Given this list of marker genes PPCDC, NOL9, TP53I3, TRAJ7, COX14, GALE, MIDEAS, SNHG1, CPHL1P, LINC02895, CDK12, CREM, VN2R3P, INTS4, CFAP418, ITK, FHOD3, ACSS2 (NCBI Gene Id 55902), COL7A1, LINC01098, CCDC18-AS1, LINC00511, ABCG1, XDH, SLC27A4, ZDHHC18, GDNF-AS1, RARA, FPR1, SALL4, CTDSPL2, SLC22A4, RPS3A, ENSG00000267174, SHKBP1, SLCO2B1, RACK1, RPL5, ZNF217, RNVU1-31, PIGT, STMN3, IKBKB-DT, RAPGEF6 (Rap guanine nucleotide exchange factor 6), SDK2, AP3S2, MATN1-AS1, ZMIZ1, PPP6R1, RFX2, MAP4K3-DT, ARMC1, DIAPH1-AS1, IMPDH1P10, OMG, SPATS2, GARS1-DT, SLC25A22, SNORD96A, EIF3F, RN7SL672P, WWTR1, ZBP1, FKBP14-AS1, COPS4, CTHRC1, OSER1-DT, LINC03033, BCAS3, ABCB9, SLC11A2, RYR2, ENDOV, ILF3-DT, ZNFX1, SRP14-DT, PARP2, COL16A1, SNHG11, RNF26, RNU7-136P, RBM22, TSSC4 (NCBI Gene Id 10078), ZFAS1, KRTAP2-4 (keratin associated protein 2-4), CCNT1, CFDP1, LINC02098, ACOT7, TRAPPC4, YJU2B, ENSG00000227496, RAB27A, PPFIA1P1, TRIB1, AIG1, EIF4A3, KLKP1, TLDC2, C9orf72, ALKBH3-AS1, CMAS, CFLAR-AS1, SNORD12C, PKIG, SNRPD1, RPS25, SMAD3, ZNF22-AS1, SP2-AS1, KRT80, SPOP, WDR62, LINC02952, KIR2DL4, SCN4B, SRP68, ZNF341-AS1, MTHFD1L, EHD1, MT-TP, RNF41, ARF4P2, ZMIZ1-AS1, MIR579, MCCC2, SNHG3, PRPF6, TRAF2, WBP2, RNU6-563P, SUN1, AXL, SNORD22, SLC2A9-AS1, NOP14-AS1, ENSG00000282849, DDX23, SNORA21, RCOR1, PCBP2, CT69, H2AX, UROD, ATP6V0A1, LINC00431, POLA2, PFDN5, DIAPH1, RN7SL418P, OSER1, SF3A3, PDLIM4, RTEL1-TNFRSF6B, HFM1, NOL4L, LINC00484, SPIDR, PAX3, ENSG00000266088, SH2D5, EIF4A1, RTEL1, RPL23, SLC12A8, RNA5SP146, MRPL38, MFAP2, RBM7P1, ACAD9, AHCYL1, GNA15-DT, DRAIC, TAOK3, RCC1, LCN2, TGFBI, ALS2, PPP4R1L, SPAG7, CHST11, VMP1, TLE3, CUEDC1, CHMP4B, PSMD1, SAP30BP, SPOCD1, MGAT5B, DUSP6, UQCC1, FAS, ENSG00000253214, RPPH1, SQSTM1, MED20, SEC22B (NCBI Gene Id 9554), LINC01615, LINC01094, KRT7, ECE1, AKNA, XIRP2-AS1, TCEA2, FPR2, AMBRA1 (NCBI Gene Id 55626), TBX1, MRGPRX4, ZNRF3-AS1, FRMD5 (NCBI Gene Id 84978), MSANTD3, SNORD30, LINC02938, RNU6-1231P (NCBI Gene Id 106480104), ILF3, TMEM170A, PI3 (peptidase inhibitor 3), RAD52, LINC02709, ADD3, OGT, PNPO, MTCO3P12, ZBTB17, ADRM1, SLC25A45, IGFBP6, LINC02454, RABAC1, BCL2L15, IL1RAP, NSG2, PHF19, SMG8, ZC3H18, WSB2, ARAP1, STARD10, NSMAF, SLC39A14, CDK17, C3, HECTD3, RNVU1-34, ELOA-AS1, P4HA2, TRIB3, here is a description of the gene set: Genes containing one or more binding sites for (TBX1) in their promoter regions (TSS -1000,+100 bp) as identified by GTRD version 20.06 ChIP-seq harmonization. Human Gene Set: TBX1_TARGET_GENES from publication Yevshin I, Sharipov R, Kolmykov S, Kondrakhin Y, Kolpakov F (PMID 30445619) species: Homo sapiens